Given this list of marker genes GAL3ST1, ST3GAL6, HACD3, ACER1, VAPA, CERS4 (ceramide synthase 4), ELOVL5, DPM3, GAL3ST3, ST8SIA1, B4GALNT1, B3GALT1, P2RX1, FUT2, ST3GAL5, ST3GAL2, GBGT1, PGAP4, PRKD3 (protein kinase D3), PIGK, SPTSSB, PGAP3, HACD1, HACD2, PIGL, ST8SIA3, PEMT, ABCG2, PIGV, ACER3, SPTLC1, B4GALT4, AGK, B4GALT6, B4GALT3, ELOVL3, ST6GALNAC3, PIGF, CCN1, SIRT3, HACD4, GAL3ST2, ST8SIA5, A4GALT, ELOVL2, CERS3, PAQR4, DPM1, CERS2, ENPP7, ST8SIA4, DPM2, SGMS1, SPTSSA, ST3GAL1, ELOVL4, ASAH2, PRKAA1, UGT8, CERS1, ASAH1, MECR, SMPD4, P2RX7, ELOVL6, PIGC, A3GALT2, ST6GALNAC4, B4GALT5 (beta-1,4-galactosyltransferase 5), ABCA8, B3GALT4, SMPD1, SLC30A5, PIGW, ABCC1, CSNK1G2 (casein kinase 1 gamma 2, NCBI Gene Id 1455), FUT9, ORMDL3, C20orf173, CLN8, PRKD1, PIGQ, PIGP, FUT4, PIGX, TM9SF2, PIGZ, ST6GALNAC6, B3GALNT1, GAL3ST4, PIGA (phosphatidylinositol glycan anchor biosynthesis class A), ACER2, CYP4F22 (NCBI Gene Id 50992), SMPD2, PIGG, GPAA1, PGAP1, ELOVL1, ZNF750, SPHK1, DEGS1, GBA1, PIGN, MFSD2B, ELOVL7, B3GALT2, PIGO, SPTLC2, PPM1L, ORMDL1, FUT1, PLA2G6, SPTLC3, ST8SIA6, PIGB, ABCA2, MPPE1, PNPLA1, PIGH, PGAP2, CWH43, ALOX12B, PIGT, PRKD2, ST6GALNAC5, ST8SIA2, CERS5, PIGU, TLCD3B, FUT6, LARGE1, FA2H, SPHK2, UGCG, PIGM, ST3GAL3, SCCPDH, PIGS, ALOXE3, PIGY, SAMD8, ST3GAL4, KDSR, B3GNT5, SGMS2, CERS6, SPNS2, DEGS2, PRKCD, OSBP, CERK, ORMDL2, CERKL, here is a description of the gene set: studied in species Homo sapiens The chemical reactions and pathways resulting in the formation of membrane lipids, any lipid found in or associated with a biological membrane. Human Gene Set: GOBP_MEMBRANE_LIPID_BIOSYNTHETIC_PROCESS